Given this list of marker genes ZIC2, SHH, FGF8, FGFR1, CRIPTO, STAG2, CDON, STIL, COL11A1, NDE1, SIX3, SUFU, ATN1, DDR2, ZSWIM6, GLI2 (NCBI Gene Id 50806), SMC1A, PTCH1, DLL1, ABCC6, PLCH1, PTCH2 (patched 2), FOXH1, TGIF1, NODAL, GAS1, DISP1, here is a description of the gene set: An abnormality of the Dura mater. studied in species Homo sapiens Abnormal dura mater morphology Human Gene Set: HP_ABNORMAL_DURA_MATER_MORPHOLOGY